Given this list of marker genes PUS1, TRIT1, TRMT10C, TRMT61B, HSD17B10, GTPBP3, MTO1, PRORP, TRMU, here is a description of the gene set: Human Gene Set: REACTOME_TRNA_MODIFICATION_IN_THE_MITOCHONDRION species: Homo sapiens tRNA modification in the mitochondrion